Given this list of marker genes VARS1, NOG, KMT2D, TELO2, EDN1, NFIX, ANKRD11, TNFRSF11A, here is a description of the gene set: A bilateral type of conductive hearing impairment. Bilateral conductive hearing impairment species: Homo sapiens Human Gene Set: HP_BILATERAL_CONDUCTIVE_HEARING_IMPAIRMENT